Given this list of marker genes SPRED2, TRIM3, CXXC1, ERG, DCLRE1A, SLC30A3, SREK1, USP49, NRP2, RPS6KA3, CDH2, ITPR1, GPAT2, MYC, E2F3, NFYC (NCBI Gene Id 54488, nuclear transcription factor Y subunit gamma), ARID4A, HOXA7, FBXO9, RNF121 (ring finger protein 121), STAG1, ODAD3, RTF1, KPNA6, ID3, NUP153, TRMT13, RIBC1, SLC6A4, EMSY, LINC01138, MEIS2, PRKCSH, SMAD6, OSBPL9, FOSL2, ZBTB18, NR4A2, NASP, CDC45, CHTF18, MCM4, ZDHHC17, PPP1R9B, MELK, UXT, UBA1, SLC6A5, FAU, CTNND2, ZNF362, POLA2, ZMYM2, SLBP, MSX1, ZFP36L2, CBX4, NFYA, DIO3, HNRNPA1, JPH1, PCNA, ETV4, SGF29, SMC1A, STMN1, NOP10, SEMA5A, WEE1, E2F1, UBE2D3, KNTC1, SH3KBP1 (SH3 domain containing kinase binding protein 1), RPUSD1 (RNA pseudouridine synthase domain containing 1, NCBI Gene Id 64723), HOXA9, INSM1, PPP1CC, EIF5A, RPA2, TRMT2A, PODN, HNRNPA3, SSTR1, CTDSP1, DDX42, PPP2R5E, MIER1, TRIM28, ADAMTS9 (ADAM metallopeptidase with thrombospondin type 1 motif 9), ARRB2, ATXN3, YPEL5 (NCBI Gene Id 51646), LGALS1, SRSF1, TMUB2, LYAR, HR, CRLS1, INTS7, SMC3, POLE2, MECOM, PRIM1, PRMT1, ADAMTSL3 (NCBI Gene Id 57188), CDK2AP1, PKN2, PPP2R1A, TRIML2, UBALD2 (NCBI Gene Id 283991), HS6ST3, OGDH, SLC38A1, RMI2, DBR1, RAD51, EVA1B, KPNB1, STAG3, ACTN4, SRSF2, UNG, TREX2, DGCR8, PHF13, HNRNPA2B1, SASS6, RBBP6, TMSB4XP8, BRMS1L (NCBI Gene Id 84312), PRRT2, TAOK3, GPD1L, RBFOX1, ZCCHC8, TPM1, EPC1, RHD, MAP3K13, NHLRC2, ARPC1A, RPS6KA5, CDC6, SP2, SIK2, SHKBP1, RANBP1, STAG2, INTS3, HMGN2, LUC7L2, PHOX2B, OSBPL7, PKMYT1, DAXX, PCYT2, DDB2, SLC38A3 (solute carrier family 38 member 3), PRKDC, SLC39A9, EZH2, KIF4A, CLSPN, CCDC107, GRIK1, FBXO5, SLC38A2, RSRC2, SIN3A, E2F7, IPO9, ZNF513, UFD1, FMO4, WASF2, PIK3R3, APLN, AREL1, BTBD10, NECTIN1, FAM219A, CBX5, ERBIN, CTPS2, FAM72A, ERH, PRRC2C, HMGB1, SYNPO, TRIB1, DDX17, OARD1, ATF7, PATZ1, CCDC47, TUBA3E, RFC1, CSRNP1, PRKACA, FCF1, BAHD1, HSBP1, SNX13, HOXA11 (NCBI Gene Id 3207), HOXB9, CA2, GPC2, GPS2, OTUD7B, ZNRF1, C1orf43, CHRM4, MRPL49, RAB11B, PPP1R8, ZBTB49, LIF, NSD3, CTCF, PDZD11, STXBP1, INTS9, ITGA1, PELO, EDRF1, CIT, RSBN1, RHCE, DNAJC11, THAP11, CDX1, BORA, TUG1, ZEB2, DNAI4, CBX3, CDKN1B, PRPF38B, KCND2, TRIM27, HMBOX1, OBI1, HNRNPD, FGF9, E2F8, VEGFB, XK, SKP2, ECE1, here is a description of the gene set: Genes having at least one occurrence of the motif NTTSGCGG in the regions spanning 4 kb centered on their transcription starting sites. This matches the E2F1 transcription factor binding site V$E2F1_Q4 (v7.4 TRANSFAC). species: Homo sapiens Human Gene Set: E2F1_Q4